The following is a description of a gene set: Genes predicted to be targets of miRBase v22 microRNA mmu_miR_223_5p in miRDB v6.0 with MirTarget v4 prediction scores > 80 (high confidence targets). studied in species Mus musculus Mouse Gene Set: MIR_223_5P from publication Chen Y, Wang X (PMID 31504780), and this is the list of marker genes: Eif4g3, Pipox, Cyp26b1, Fmo6, Mmp16, Tent5a, Ctdsp1, Efnb2, Mtor, Iqck, Lrrc74b, Micu2, Tm2d2, D630023F18Rik, Aftph, Abhd17b (abhydrolase domain containing 17B, NCBI Gene Id 70566), D17H6S53E, Rbbp7, Phf21b, Cfap20, Zfp1009, Prpsap2, Gtpbp2, Srp19, Papss1, Zfp641, Hs2st1, Rassf8, Kcnj14, Klf10, Mtf2, Tank, Atp2a2, Snrnp27, Ntrk3, Arxes2, Brwd3, Ranbp10, Loxl4, Sema3a, Mak16, Sptlc3, Hpgds, Cplx2 (NCBI Gene Id 12890), Tnfrsf21, Rgs7bp, Cip2a, Lrp6, Zbtb10, Sec23ip, Cnot7, Slc7a11, Vrk1, Lrat, Slc25a31, Txlnb, Cyp2c65, Nsd3, Dop1a, Zfp697, Fndc3b, Rras2, Calr3, Tmem220, Wdr86, Pak3, Irx2, Zfp781b, Colec10, Gabrb3, Adgrf5, Dclk1, Aktip, Med12, Ankrd26, Ncf1, Orc3, Irf4, Fbxl22, Zfp819, Lrrc19, Mageb4, Pcdh7, Plac9, Tars3, Mideas, Ankrd17, Tmeff1, Atad1, Naa30, Snap23, Mgat4a, Aldh1l2 (NCBI Gene Id 353070), Zfp738, Fuz, Pbrm1, Atp2b2, Nrxn1, Hmx2, E2f8, Gm8369, Hhip, Nhsl1, Fbxo5, Smad9, Ddx19b, Cyp2j6, Sh2d2a, Mctp1, Gosr1, Ywhaq, Fezf1, Pcmtd1, Spidr (scaffolding protein involved in DNA repair), Lyg2, Twsg1, Rab14, Rab6a, Ercc6l2, Fbxl2, Ptk7, Zfp930, Zfpm2, Slc2a1 (NCBI Gene Id 20525), A130010J15Rik, Far2, Acss3, Treml2, Synj2bp, Lpp, Twf1